Given this list of marker genes Rpl10, Rpl13, Csl, Rack1, Rps8, Rpl30, Rpl18a (ribosomal protein L18A), Eef1g, Rpl32, Rps14, Rps3, Rpl28, Rpl7, Rps27a, Rpl4, Tmem121b, Uba52, Rpl5, Tpt1, Rpl36a, Rpl23, Rpl18, Nbea, Eif3h, Rpl13a, Sin3b, Rbbp6, C8g, Rpl29, Eef1a1, Rpl15, Eef1b2, Qars1, Rps9, Rps5, Rps16, Rps6, Rps23, Rps19, Rpl6, Eif4b, Rpl27a, Rpl24, Rpl21, Rps17, Eif3f, Eif3m, Spry2, Nop53, Rps13, Rps7, Use1, Exd2, Gm5766, Rps25, Rps3a1, Lta4h (NCBI Gene Id 16993), Rpl26, Rps10, Cox7a2l, Rpl14, Eef2, Rps24, Ptms, Rpl8, Eif3l, Kcnk13, Rpl7a, Rps4x, Fau, here is a description of the gene set: The tuberous sclerosis complex (TSC) proteins TSC1 and TSC2 regulate protein translation by inhibiting the serine/threonine kinase mTORC1 (for mammalian target of rapamycin complex 1). However, how TSC1 and TSC2 control overall protein synthesis and the translation of specific mRNAs in response to different mitogenic and nutritional stimuli is largely unknown. We show here that serum withdrawal inhibits mTORC1 signaling, causes disassembly of translation initiation complexes, and causes mRNA redistribution from polysomes to subpolysomes in wild-type mouse embryo fibroblasts (MEFs). In contrast, these responses are defective in Tsc1(-/-) or Tsc2(-/-) MEFs. Microarray analysis of polysome- and subpolysome-associated mRNAs uncovered specific mRNAs that are translationally regulated by serum, 90% of which are TSC1 and TSC2 dependent. Surprisingly, the mTORC1 inhibitor, rapamycin, abolished mTORC1 activity but only affected approximately 40% of the serum-regulated mRNAs. Serum-dependent signaling through mTORC1 and polysome redistribution of global and individual mRNAs were restored upon re-expression of TSC1 and TSC2. Serum-responsive mRNAs that are sensitive to inhibition by rapamycin are highly enriched for terminal oligopyrimidine and for very short 5' and 3' untranslated regions. These data demonstrate that the TSC1/TSC2 complex regulates protein translation through mainly mTORC1-dependent mechanisms and implicates a discrete profile of deregulated mRNA translation in tuberous sclerosis pathology. Mouse Gene Set: BILANGES_SERUM_AND_RAPAMYCIN_SENSITIVE_GENES Genes translationally regulated in MEF cells (embryonic fibroblasts) in response to serum starvation and by rapamycin (sirolimus). from publication Bilanges B, Argonza-Barrett R, Kolesnichenko M, Skinner C, Nair M, Chen M, Stokoe D (PMID 17562867) species: Mus musculus